Given this list of marker genes CREB3L2, TMED4, LMAN2, SMOC1, UQCR10, SNAP25, DAB2IP, SLC26A3, BSDC1, CUTA, ZSWIM3, PAPLN, ZBTB40, NKX2-2, POU5F1, LRFN4, OBSCN (obscurin, cytoskeletal calmodulin and titin-interacting RhoGEF), CREB1, NRAP, PPARA, PRKAG1, RAPGEF6, WRAP53, PRDM16, CNTFR, OVOL1, SYT6, SLC22A18, SLC25A4, ADRB2, GLTP, APOM, SLC7A9, RPRD1B, CRYBG2, GPD1, PRKCD, SEC22B, STT3B, HNF1B, MAP3K11, CLUH, PTPRG, ACSF2, HOXD10, GOLGA4, SCNM1, VWCE, CCDC71, G6PC1, HIKESHI, LRRC19, NEUROG2, KCNE5, LYSMD1, FAM170A, TGIF1, DIS3L, MARCKSL1, CALB1, ARFGEF2 (ADP ribosylation factor guanine nucleotide exchange factor 2), NR2C2, IGF1R, MYH10, RAB33A (RAB33A, member RAS oncogene family), ACOT8, ZFHX3, BAZ2A, RHOB, CCER1, PDZK1, NET1, PSME3IP1, PATZ1, SLC25A5, FGF10, SLC25A47, PAK4, CALHM1, HSPE1, ARL6IP6, TRPC5, PAN2, TBX5, SS18, TAOK3, HOXD3, PRG4, EEF1B2, PTBP2, SERPINF1, CHRDL1, ZIC4, IYD, PTMS, ZNF792, RTN4, C4B, MOV10 (NCBI Gene Id 57723), PKP4, CDHR5, ILRUN, PLPPR1, NR1H3, ZBTB18, UBE4A, ITGA1, LTB4R2, TTI1, F2, PLEC, PCK1, LMX1B, RARB, NEK6, PRKCSH, VCPIP1, SLC25A25, ZNF777, LINS1, CLRN3, ATAT1, ADGRA2, GAPDH (glyceraldehyde-3-phosphate dehydrogenase), AKT2, TPI1, GATA4, POLR2H, PCBP4, GCC2, CACNB2, SP8, GIPC2, SLC26A6 (solute carrier family 26 member 6), FKBP5, HNF1A, TOMM70, PFKFB1, ATN1, SRSF4, HTN1, MED8, MRPS28, SZT2, ADAMTS19, TP53, AGPAT1, RTP3, NHERF4, KLHL1, HSPD1, C1orf116, CREBRF, SLC22A18AS, HR, CDIN1, JMJD1C, C1orf210, PKLR, EIF4G1, INSR, MYRF, SLC25A1, SELENOP, GCH1, SHFL, PAFAH2, SAMD14, PDLIM7, RSPRY1, SELENOM, TMEM120A, KYNU, EDN3, MARK2, SCT, NDUFS1, MREG, MLEC (malectin), PRRX2, CKMT1B (creatine kinase, mitochondrial 1B), CSRNP3, GBF1, ARL6IP1, PELO, C4A, UBE2R2, PRR14, SATB1, PGF, CBX7, NTNG2, SESN3, TRAF4, PEX16, PDE3B, CDX2, PPP1R14D, CDK16, SLC34A1, COL15A1, PABPN1, SLC7A7, RNF5, TLK2, ASB7 (ankyrin repeat and SOCS box containing 7), SEC24C, RBMS1, HDAC4, CTAGE1, PPARGC1A, SRSF6, HOXA10, DNAJA2, CDH6, FABP2, NYAP1, FLNC, MAF, SOX5, SEMA3B, SHF, F10, MLLT6, GMPPB, LRP1, PPARG, ETFDH, LEAP2, TMEM40, PDIA4, BCL11B, AKAP11, PAX7, CRABP2, NGEF, SMYD5, AP1B1, RBP2, RPS3A, LPL, ACOT7, ARCN1, HOXA9, ASXL1, GBE1, SNCB, ABI3BP, ARPIN, PITX2, DUSP3, PIP4K2A, ODAD3, INHBC, CLCN2, EPHA3, WDR82, MPC2, SPRY4, TIMELESS, PRDM1, NIPSNAP1, SEC16B, SLC23A3, WNT3 (NCBI Gene Id 7473), IFFO1, LRRN1, RNF103, ERBB3, LGALS4, F13B, RASGRP2, PDE8A, here is a description of the gene set: Human Gene Set: HNF4_01 studied in species Homo sapiens Genes having at least one occurrence of the motif NNNRGGNCAAAGKTCANNN in the regions spanning 4 kb centered on their transcription starting sites. This matches the HNF4A transcription factor binding site V$HNF4_01 (v7.4 TRANSFAC).